The following is a description of a gene set: Genes downstream of both CDKN1A and TP53 in 2774qw1 cells (ovarian cancer). studied in species Homo sapiens from publication Wu Q, Kirschmeier P, Hockenberry T, Yang TY, Brassard DL, Wang L, McClanahan T, Black S, Rizzi G, Musco ML, Mirza A, Liu S (PMID 12138103) Human Gene Set: WU_APOPTOSIS_BY_CDKN1A_VIA_TP53 In this study we used adenovirus vector-mediated transduction of either the p53 gene (rAd-p53) or the p21(WAF1/CIP1) gene (rAd-p21) to mimic both p53-dependent and -independent up-regulation of p21(WAF1/CIP1) within a human ovarian cancer cell line, 2774, and the derivative cell lines, 2774qw1 and 2774qw2. We observed that rAd-p53 can induce apoptosis in both 2774 and 2774qw1 cells but not in 2774qw2 cells. Surprisingly, overexpression of p21(WAF1/CIP1) also triggered apoptosis within these two cell lines. Quantitative reverse transcription-PCR analysis revealed that the differential expression of BAX, BCL2, and caspase genes, specific in rAd-p53-induced apoptotic cells, was not altered in rAd-p21-induced apoptotic cells, suggesting p21(WAF1/CIP1)-induced apoptosis through a pathway distinguishable from p53-induced apoptosis. Expression analysis of 2774qw1 cells infected with rAd-p21 on 60,000 cDNA microarrays identified genes in response to p21(WAF1/CIP1) expression in at least one time point with 2.5-fold change as a cutoff. Integration of the data with the parallel microarray experiments with rAd-p53 infection allowed us to extract genes downstream of both p53 and p21(WAF1/CIP1) and genes in response to p21(WAF1/CIP1) expression in a p53-independent pathway. The genes in the former set may play a dual role in both p53-dependent and p53-independent pathways, and the genes in the latter set gave a mechanistic molecular explanation for p53-independent p21(WAF1/CIP1)-induced apoptosis. Furthermore, promoter sequence analysis suggested that transcription factor E2F family is partially responsible for the differential expression of genes following p21(WAF1/CIP1). This study has profound significance toward understanding the role of p21(WAF1/CIP1) in p53-independent apoptosis., and this is the list of marker genes: PARP2, CCN1, RRM1, RACGAP1, SMC2, ASPM, TCN2, TUBA1A, MKI67, AURKA (NCBI Gene Id 8465), ANLN, UBE2C, TUBB4A, FAT2, WDHD1, MIS18BP1 (MIS18 binding protein 1), TRIM44, SERPINI2, TUBB3, CDK1, ZBTB5, MCM3, KNTC1, EXO1, PBK, CEP55 (centrosomal protein 55), MCM4, NCAPD3, VEGFA, UBE2T, NCAPG, PRC1, HMGB1P5, HNRNPA2B1 (NCBI Gene Id 3181), P4HA1, DLGAP5, BIRC2, TPX2, CDC25B, TTK, FANCI, SPDL1, ATAD2, MCM6, HMGB2, MCM2, BUB1 (BUB1 mitotic checkpoint serine/threonine kinase), ZNF84, CCNB1, TYMS, CDKN1A, AURKB, NPM1